Given this list of marker genes DDR1, EXOC6, FGF7, ECSIT, TGFB1, NRF1, LOXL4, NQO1, IGFBP7, FN1, CDC37, ANXA5, PKD1, SIRT1, SUV39H1, NFE2L2, BMP2, COL2A1, here is a description of the gene set: Interactions between LOXL4 and oxidative stress pathway Human Gene Set: WP_INTERACTIONS_BETWEEN_LOXL4_AND_OXIDATIVE_STRESS_PATHWAY species: Homo sapiens